Given this list of marker genes Agk, Timm22, Timm10 (NCBI Gene Id 30059), Timm9, Timm29, Timm10b, Trmt10b, here is a description of the gene set: Mouse Gene Set: GOCC_TIM22_MITOCHONDRIAL_IMPORT_INNER_MEMBRANE_INSERTION_COMPLEX A multi-subunit complex embedded in the mitochondrial inner membrane that mediates the inner membrane insertion of multi-transmembrane spanning proteins that contain internal targeting elements. In yeast cells, TIM22 is a 300-kDa complex, consisting of four membrane integral subunits, Tim22, Tim54, Tim18 and Sdh3, and a peripheral chaperone complex consisting of the small TIM proteins, Tim9-Tim10-Tim12. species: Mus musculus